The following is a description of a gene set: from publication Yevshin I, Sharipov R, Kolmykov S, Kondrakhin Y, Kolpakov F (PMID 30445619) Genes containing one or more binding sites for (IGF1R) in their promoter regions (TSS -1000,+100 bp) as identified by GTRD version 20.06 ChIP-seq harmonization. studied in species Homo sapiens Human Gene Set: IGF1R_TARGET_GENES, and this is the list of marker genes: RPL34P10, IGF1R, MT-RNR1, MT-TF, SENP2